Given this list of marker genes ETS1, FCGR3B, CAST, TREX1, PXK, SLC46A1, GJB6, AP1S3, IL36RN, FERMT1, STAT4 (NCBI Gene Id 6775), IL17RC, SLC39A4, ICOSLG, TMPRSS6, C4A, TNFSF4, CR2, IRAK1, TNFAIP3, C4B, JAZF1, AMN, MALT1, ITGAM, KRT16, GJB2, KRT6B, BLK, KRT17, IL17RA, UBE2L3, PDCD1 (NCBI Gene Id 56179), PKP1, CLEC7A, TLR7, OCRL, HLA-DRB1, BLM, TRAF3IP2, IRF5, CUBN, TNIP1, PTPN22 (NCBI Gene Id 5779), SREBF1, IL10, KRT6A, DNASE1, FCGR2B, CTLA4, BANK1, IGHG1, KIAA0319L, PERP, IL17F, DSC3, SPP1, MBTPS2, MECP2, here is a description of the gene set: studied in species Homo sapiens Inflammation of the lip. Cheilitis Human Gene Set: HP_CHEILITIS